The following is a description of a gene set: studied in species Mus musculus Genes predicted to be targets of miRBase v22 microRNA mmu_miR_6930_5p in miRDB v6.0 with MirTarget v4 prediction scores > 80 (high confidence targets). Mouse Gene Set: MIR_6930_5P from publication Chen Y, Wang X (PMID 31504780), and this is the list of marker genes: Plekhd1, Tmem104, Pfn1, Foxp4, Jade1, Arhgdia, Hs3st4, Ube2l6, Gm57857, Zbtb16, Prss35, Lig4, Smc1a, Esp1, Rbm12b1 (RNA binding motif protein 12 B1), Plxna1, 2610528J11Rik, Scd4, Ppp1r1c